The following is a description of a gene set: Any process that stops, prevents, or reduces the frequency, rate or extent of calcium-mediated signaling. studied in species Homo sapiens Human Gene Set: GOBP_NEGATIVE_REGULATION_OF_CALCIUM_MEDIATED_SIGNALING, and this is the list of marker genes: CHP1, MYOZ2, SLA2, GSK3B, RCAN1, MTOR, ATP2B4, HOMER3 (NCBI Gene Id 9454), HOMER2, FHL2 (four and a half LIM domains 2), TBC1D10C (TBC1 domain family member 10C), MAPK7, INPP5A, ACTN3, DYRK2, PLEK, FKBP1B, PRNP, MYOZ1, ITPR1, SLC24A4, CD22